The following is a description of a gene set: Synthesis of PIPs at the late endosome membrane species: Homo sapiens Human Gene Set: REACTOME_SYNTHESIS_OF_PIPS_AT_THE_LATE_ENDOSOME_MEMBRANE, and this is the list of marker genes: MTMR4, PIKFYVE, FIG4, MTMR2, PIK3C3, MTMR7, VAC14, MTMR9, MTM1, PIK3R4, PIK3C2A